Given this list of marker genes TMED2, HEY2, PLCD3, DNAJB6, SENP2, PCDH12, BIRC6, ZFP36L1 (NCBI Gene Id 677), SPINT1, SPINT2, CDX2, NCOA1, FGFR2, CCN1, CASP8, NSDHL, CDX4, JUNB, VASH2, GJB5, MAP2K1 (mitogen-activated protein kinase kinase 1), GCM1, VASH1, PLG, RSPO3, ST14, HES1 (NCBI Gene Id 3280), ADM, MAPK1, EGLN1, FBXW8, HEY1, RBPJ, BMP5, GRB2, WNT7B, CITED1, AKT1, LLGL2, BMP7, WNT2, FZD5, GRHL2, SOCS3, LEF1, GGNBP2, OVOL2, IL10, HS6ST1, here is a description of the gene set: Human Gene Set: GOBP_LABYRINTHINE_LAYER_DEVELOPMENT studied in species Homo sapiens The process in which the labyrinthine layer of the placenta progresses, from its formation to its mature state.